The following is a description of a gene set: Regulation of GF-RTK-RAS-ERK signaling, RAS ubiquitination by CUL3 complex. Pathway ID: N01596. Pathway type: Reference. Pathway class: nt06526 MAPK signaling. Pathway Definition from KEGG: (LZTR1+CUL3) -| (RAS,RIT1) species: Homo sapiens Human Gene Set: KEGG_MEDICUS_REFERENCE_REGULATION_OF_GF_RTK_RAS_ERK_SIGNALING_RAS_UBIQUITINATION_BY_CUL3_COMPLEX, and this is the list of marker genes: NRAS, HRAS, LZTR1, KRAS, CUL3, RIT1